Given this list of marker genes LPAR4, LPAR2, LPAR3, LPAR6, LPAR1, here is a description of the gene set: studied in species Homo sapiens Human Gene Set: GOMF_LYSOPHOSPHATIDIC_ACID_RECEPTOR_ACTIVITY Combining with the phospholipid derivative lysophosphatidic acid, and transmitting the signal across the membrane by activating an associated G-protein.